The following is a description of a gene set: Genes predicted to be targets of miRBase v22 microRNA mmu_miR_6925_3p in miRDB v6.0 with MirTarget v4 prediction scores > 80 (high confidence targets). studied in species Mus musculus from publication Chen Y, Wang X (PMID 31504780) Mouse Gene Set: MIR_6925_3P, and this is the list of marker genes: Rtn4, Atad2b, Slc1a4, Plekhh2, Pla1a, Nfib, Shf, Lpcat3, Pdhb, Pakap, Thbs2, Gpat3, Hspbap1, Slc16a10, Ppm1h, Plppr5, Nfkb2, Ube2k, Srsf1, B3galt1, Otub1, Nckap1l, Zfp68, Bach2, Adipor2, Dpf1, Arl6ip1, Tnf, Itga2, Dip2b, Aqp3, Mtarc1, Gng12, Meis2, Gata2, Hdac8, Cnr1, Sh3bgrl2, Ppfibp2, Cnnm4, Plekhg1, Fam110c, Ddx6, Txlnb, Reep2, Adgra2, Klf11, Kras, Pla2g3, Nrp2, Plek, Elavl3, Ppp3ca, Vwa8, Tmem240, Lrrc4, Abcc4, Ptprr, Stard13, Gnpnat1 (glucosamine-phosphate N-acetyltransferase 1), Prrc2b, Acsl1, Sgip1, Zfhx4, Glul, Brd8dc, Nfia, Dis3l2, Nr4a2, Tmod2, Ccnd2, Rhobtb3, Cacnb2, Stradb, Rora, Nfasc, Apol10b (NCBI Gene Id 328561, apolipoprotein L 10B), Ube2m, Nudt19, Prox1, Tmtc2, Scn1a, Ankrd6, Orai2, Btbd3, Xirp2, Spata13, Esp6, Amfr, Cltc (clathrin heavy chain), Ikzf2, Lenep, Arpc1a, Phox2b, Oit3, Cd320, Fxr1, Resf1, Kansl1